The following is a description of a gene set: studied in species Homo sapiens Human Gene Set: HP_PREMATURE_VENTRICULAR_CONTRACTION Premature ventricular contraction Premature ventricular contractions (PVC) or ventricular extrasystoles are premature contractions of the heart that arise in response to an impulse in the ventricles rather than the normal impulse from the sinoatrial (SA) node., and this is the list of marker genes: RYR2, TNNI3K (TNNI3 interacting kinase), DOHH, SCN5A, CDH2, MYZAP, DPP6, DEPDC5, CNBP, TMEM43, CALM2, NAA10, JUP, TRDN, CALM1, PKP2, DSG2 (NCBI Gene Id 1829, desmoglein 2), RYR1, NFIX, KCNE1, CASQ2, DSP, KCNJ5, TANGO2, TECRL, KCNJ2, TOR1AIP1, SLC25A20 (solute carrier family 25 member 20), CACNA1S, VEZF1